Given this list of marker genes Polr3a, Prim2, Polr1b, Polr3b, Polr1a, here is a description of the gene set: Binding to a RNA/DNA hybrid. species: Mus musculus Mouse Gene Set: GOMF_DNA_RNA_HYBRID_BINDING